Given this list of marker genes PIK3CA, THOC5, PIK3CB, GRAP2, IL34, UBC, FYN, INPPL1, PLCG2, CSF1, CSF1R, GAB2, INPP5D, UBB (ubiquitin B), STAT3, PTPN11, SRC, LYN, UBA52, SHC1, GAB3, STAT1, SOS1, YES1, CBL, RPS27A, KRAS, PIK3R1, GRB2, HCK, PIK3CD, here is a description of the gene set: Signaling by CSF1 (M-CSF) in myeloid cells studied in species Homo sapiens Human Gene Set: REACTOME_SIGNALING_BY_CSF1_M_CSF_IN_MYELOID_CELLS